Given this list of marker genes SOWAHC, IRAG1, CLK4, SPRED1, HMGXB4, FAM110A, ELL2, MAN1C1, EOLA1-DT, SNTB2, FUCA1, ZDHHC20, SLC6A6, XAB2, RBP7, RAB14, DYRK1A, SCARB2, SRBD1, FPR2, HAPSTR2, MAP2K3, BLTP1, NFATC1, KNDC1, KCNE1, SWAP70 (NCBI Gene Id 23075), LRPAP1, SLC44A2, SESN1 (NCBI Gene Id 27244), INPP5A, UPP1, SCPEP1 (NCBI Gene Id 59342), BACH1, LST1, TUBA4A, KRT23, IL10RB, RAB24, RASA1, ZBTB11, MXI1, MIIP, TESC, KLHL2, C3AR1, ADAP2, TBC1D8, LTA4H, C3, ITPRID2, LAPTM4A, CENPE, SLC2A6, RHOC, HEY1, L1TD1, EXT1, TMC6, DENND6A, UBASH3B, REEP3, CD300LF, STK32C, PLAGL2, HAUS8, TP53INP1, KDM1B, WIPI1 (NCBI Gene Id 55062), RNF144B (NCBI Gene Id 255488), SMPDL3A, NPC2, SERPINA1, AGA, MBD2, CUEDC1, FYB1, TRIQK, SLC11A1, HEG1, GBP2 (NCBI Gene Id 2634), RRAS, NEK7, RNF135, GNL3L, GPR155 (G protein-coupled receptor 155), CCSAP, PTGES3, DUSP7, CHST15, TADA3, SYTL1, ADGRE1, VNN2, NXPE3, MAN1A1, ING3, LNPEP, SNX5, LMO2, TMEM116, SH2D3C, CNEP1R1, ASAH1, MKRN1, CPEB4, REST, MAPKAPK3, PAPSS1, MBOAT1, TLR1, MCOLN1, ZBTB7A, PECAM1, SLAIN2, ZBTB16, VPS53 (NCBI Gene Id 55275), MDM2, CCNG2, BORCS8, EAF2, DEDD2, TMOD3, CNIH4, SPAST, TMPO-AS1, AIF1, LIMS3 (NCBI Gene Id 96626), TNFRSF14, SFN, RIOK3, DAPK1, HIVEP1, OSTM1, H2AZ1, DUSP6, FFAR2, PTPRC, ZCCHC7, CCDC88C, CRLF3, NPL, NTAN1, CDS2, APH1B, CYBRD1, NADK, NACA, ST3GAL5, CMTM2, KIAA0232, PLXNC1, ITGB1, MERTK, DUSP5, CAMK1, PRORSD1P, OSBPL8, SIPA1L1, RHBDF2, SECTM1, LDLRAD3, P2RX1, MED13L, KCTD9, CMTM6 (NCBI Gene Id 55487), IQCK, SP3, RP2, GPR137B, SFTPD, PIK3R1, FMR1, MTMR6, CD79B, CHMP1A, TWF1, HK3, TNFRSF1B (TNF receptor superfamily member 1B), CCPG1, N4BP1, TMEM139, MSN, ABHD3, DAZAP2, GPBAR1, VNN1, DHRS12, ME2, IER5, FCER1G, SPOPL, MAST3, EVI2B, ITGA4, CYREN, SDHB, SOD2 (superoxide dismutase 2), here is a description of the gene set: Genes up-regulated in CD16- monocytes versus dendritic cells. In this study gene expression of human blood classical monocytes (CD14++CD16-), CD16 positive monocytes (consisting of non-classical CD14+16++ and intermediate CD14++CD16+ monocytes) and CD1c+ CD19- dendritic cells from healthy subjects were investigated. species: Homo sapiens Human Gene Set: GSE34515_CD16_NEG_MONOCYTE_VS_DC_UP from publication Frankenberger M, Hofer TP, Marei A, Dayyani F, Schewe S, Strasser C, Aldraihim A, Stanzel F, Lang R, Hoffmann R, Prazeres da Costa O, Buch T, Ziegler-Heitbrock L (PMID 22531920)